The following is a description of a gene set: A trimeric protein complex that phosphorylates inhibitory-kappaB (I-kappaB) proteins. The complex is composed of two kinase subunits (alpha and beta) and a regulatory gamma subunit (also called NEMO). In a resting state, NF-kappaB dimers are bound to inhibitory IKB proteins, sequestering NF-kappaB in the cytoplasm. Phosphorylation of I-kappaB targets I-kappaB for ubiquitination and proteasomal degradation, thus releasing the NF-kappaB dimers, which can translocate to the nucleus to bind DNA and regulate transcription. species: Mus musculus Mouse Gene Set: GOCC_IKAPPAB_KINASE_COMPLEX, and this is the list of marker genes: Ikbkb, Trim40, Pycard, Erc1, Chuk, Ikbkg